Given this list of marker genes DNAI1, RUNX2, CTSK, NOTCH2, COL11A1, TRIM37, ATRX, FLNA, here is a description of the gene set: Absent frontal sinuses Human Gene Set: HP_ABSENT_FRONTAL_SINUSES studied in species Homo sapiens Aplasia of frontal sinus.